Given this list of marker genes CCDC8, CUL7, FBXW8, OBSL1, ANKRA2, here is a description of the gene set: species: Homo sapiens Human Gene Set: GOCC_3M_COMPLEX A protein complex, at least composed of CUL7, CCDC8 and OBSL1, that is required for maintaining microtubule and genome integrity.